Given this list of marker genes CFH, PLAUR, SEC11A, FCN2, IMMP1L, MBL2, SPCS3, SPCS1, PLAU, F7, F3, IMMP2L, COLEC11, THBD, COLEC10, SEC11C, FCN1, SEC11B, HTRA2, FCN3, SPCS2, here is a description of the gene set: studied in species Homo sapiens Human Gene Set: GOCC_SERINE_TYPE_PEPTIDASE_COMPLEX A protein complex which is capable of serine-type peptidase activity.